The following is a description of a gene set: from publication Shinohara H, Behar M, Inoue K, Hiroshima M, Yasuda T, Nagashima T, Kimura S, Sanjo H, Maeda S, Yumoto N, Ki S, Akira S, Sako Y, Hoffmann A, Kurosaki T, Okada-Hatakeyama M (PMID 24833394) Genes down-regulated in B lymphocytes: untreated versus anti-IgM for 1h. The activation signaling of transcription factor nuclear factor-kB (NF-kB) plays central role for immune system. One of key kinase mediating this pathway is TAK1 in adaptive and innate immunity. However, role of TAK1 in B cell receptor signaling is still unclear. To know effects of TAK1-deletion on the gene expression induced by anti-IgM, we performed the time course analysis in comparison of wild type with TAK1-deleted splenic B cells. studied in species Homo sapiens Human Gene Set: GSE41176_UNSTIM_VS_ANTI_IGM_STIM_BCELL_1H_DN, and this is the list of marker genes: GLUL, CRBN, NCKAP1L, SEPTIN7 (septin 7), NPC2, MYO1F (myosin IF), CD101, RPL34, SLC31A2, RNF5, DNAJC13, TRIOBP, RNASE4, LAP3, TMEM50A, RNF34, STAT1, VPS35L, RPL10, PRCP, CNOT8, MYD88, FCGR1BP (NCBI Gene Id 440607), KLF11, PLSCR3, EDC4 (enhancer of mRNA decapping 4), DHRS7, IDS, RNF130, SH3BGRL, IFFO1, IL1R2, MSRB1, MICB, HTRA1, SORT1, KIAA0513, GDE1, PYGL, FYB1 (FYN binding protein 1), RPS11, MSRA, FPR3, PECAM1, CSF1R, IFIT5, LIN37, MAP3K2, OAS1, ARL6IP5, EPRS1, BMAL1, ALOX5, CXCL9, PCNA, ATF5, ARF3, C1GALT1, COMMD9, GSN, OSBPL11, VAMP5, ALDH2, NHEJ1, SNHG32, HHEX, MBD2, CXCL10, SLC25A1, CTNND1, TGFBI, CLEC2B, POLD3 (DNA polymerase delta 3, accessory subunit), TMEM51, SLFN12, MNT, RPL35A (ribosomal protein L35a), CHRNB1, TPI1 (triosephosphate isomerase 1), PCCA, RPL41, ITPK1 (NCBI Gene Id 3705), PSMB9, MAP4K3, NAIP, PRPS2, MYOF, KBTBD4, CD52, FN1, APOBEC3A, IL13RA1, EVI2B, HINFP, SLC25A14, THEMIS2, TMEM243, HLA-DMA, TAF5, RPL21, LSP1, XRCC1, F11R, CXCL11, FGL2, SLC16A5, RNF141, DDAH2, TNFSF10, MPC1, PSAP, ST8SIA4, ZNF184, ATRN, MCCC1, ADAMTS5, TAP1, RASSF2, SIGIRR, CEBPD, GPX7, RPL36A, HEXIM1, HEXB, C1orf54, LGALS9, SORL1, SOCS6, GCNT1, ARF5, DOCK2, IFIT2, RPL29, USP3, VASH1, ANXA4, COX4I1, HMOX1, ROGDI, NTAN1, TMX4, FCGR3B, HMG20B, DENND1B, CASS4, RGS19, LTA4H, WIPI2, RPS29, IFI16, HLA-DPB1, CD86, KCNAB2, TNS1, RPL18, RNASE6, SCARB2, CCDC28A, PAPSS1, CPT1A, MVP, CELF2, UFC1, TMT1A, BIN2, C5AR2, EVI2A, THAP11, VCL, CD36, PSME1, VRK2, FAM89B, H2AC6, AKR7A2, CTSB, CNDP2, RFXANK, FUCA1, TIMP2, SNTB2, MNDA, RPL27, BMP2K, GRN, MGST3, TMEM126B, HAUS4, JAK2, ACAA1, NOD2, ACP5, CALHM2, TMEM164 (NCBI Gene Id 84187), HSD17B11 (NCBI Gene Id 51170), TBC1D1, ICAM2, MCUB, FRAT1